The following is a description of a gene set: species: Mus musculus Mouse Gene Set: GOBP_POSITIVE_REGULATION_OF_BASEMENT_MEMBRANE_ASSEMBLY_INVOLVED_IN_EMBRYONIC_BODY_MORPHOGENESIS Any process that activates or increases the frequency, rate or extent of basement membrane assembly involved in embryonic body morphogenesis., and this is the list of marker genes: Phldb2, Dag1, Phldb1, Clasp1, Clasp2